Given this list of marker genes PLA2G7, RGS2, NRP2, CCL3, VASP, TSPAN15, TRPS1, TMEM26, PIP, CD24, TMPRSS11D, HCK, HPSE, RRBP1, SEMA7A, ARHGAP11A, SESN3, DUSP6, CD180, SEMA4B, ARFRP1, ARFGEF2, PTPN14, MYB, SIPA1, ACSL4, CLEC4E, PLA2G2D, NAP1L3, NEDD4L, LAIR1, DAB1, FBXL5, HDHD5, CD8A, TLR8, RND3, TCF7, PLXNC1, CYBB, CCDC134, TYROBP, NKG7, SH3TC1, S1PR3, ANKRD17, IER3, CXCL2, CD19, CBLB (Cbl proto-oncogene B), PIK3AP1, PHF19, CCDC38, KCNJ10, PDE4D, MAP3K5, RILPL2, EIF4G2, GPR156, RGS10, CENPC, ZC3H12C, SLC25A37, NEDD4, MYOF, UBE2R2, ATP6V0E1, SCN2B, PTGER4, ATP6V0B, CUEDC1, ACKR3, CYP39A1, KIF15, CLEC4D, SLC41A2, ITPR2, GADD45B, PLK2, CD93, IFT22, LY9, DUSP5, NAB1, VPREB3, RNF145, SORBS2, PXDN, LAT, SLC28A2, COX6B1, MS4A7, NDUFA4, SPNS3, DPH5, TRAPPC1 (trafficking protein particle complex subunit 1), TRIAP1, INPP4A, TAOK3, TET1, PIK3R4, S100A8, PADI2, MTMR4, PLA2G4A, CAPSL, ZFYVE21, ARL5C, GMPR2, IL18, TLR6, CDH17, TXN2, SLC66A1, POLM, CIB1, MYL4, GCOM1 (GCOM1, MYZAP-POLR2M combined locus), CD274, LTK, CR2, KLHL7, PIP4K2A, BCO2, SNRNP70, SLC15A3, DISC1, EPS15, ACAP1, PTPRJ, ELL3, DZIP1, CD38 (NCBI Gene Id 952), HCAR2, CD226, JAML, POLB, CPD, ERP44, PLAC8, BLNK, TSGA13, LUZP2, ZEB2, SPRR2E (NCBI Gene Id 6704), ASB2, FCRL5, LIPC, CLTA, PTAFR, PDXK, BZW2, TLR3, BMF, CFP, PDXP, NCAPD3, EDARADD, RFC2, TBC1D9, PRF1, ALPK2, GAPT, SYVN1, IFI30, SEMA5A, CYP4B1, GRAMD1B, SLC29A3, MARCKS, SLAMF1, BAZ1A, EYA1, EIF4G1, RB1, here is a description of the gene set: Cells from four develppmental stages were purified by FACS from human bone marrow samples studied in species Homo sapiens Human Gene Set: GSE4590_SMALL_VS_LARGE_PRE_BCELL_UP from publication Hoffmann R, Lottaz C, Kühne T, Rolink A, Melchers F (PMID 17890238) Genes up-regulated during B lymphocyte differentiation: small pre-B II versus large pre-B II.